Given this list of marker genes Socs1, Rhoh, Rc3h2, Ppp2r3c, Slc25a5, Il1rl2, Clcf1, H2-Aa, Slc4a2 (solute carrier family 4 (anion exchanger), member 2), Cyld, Rora, Prr7, Lmbr1l, Pck1, Cd27, Pax1, Mmp14, Cd3d, Il1a, Tusc2, St3gal1, Mir19a, H2-Oa (histocompatibility 2, O region alpha locus), Gimap1, Ptpn22, Bcl2a1d, Smarcc2, Bcl2, Tnfsf8, Foxj1 (NCBI Gene Id 15223), Zfp608, Dll4, Ccr9, Pglyrp2, Ccr6, Chd7, Smarca4, Ikzf1, Il23a, Gimap3, Il12b, Fas, H2-Ea, Ms4a1, Il2ra, Prelid1 (NCBI Gene Id 66494), Zeb1, Foxn1, Opa1, Armc5, Lrrc8a, Ctla2a, Mpzl2, Cd83, Brd4 (NCBI Gene Id 57261), Dtx1, Igkc, Pcid2, Dcaf1, Enpp1, Il9r, Brd2, Pou2af1, Traf3ip2, Lig4, Btk, Mtor, Pbrm1, Lilrb4a, Klhl25, Spib, Clec4g, Ripk3, Adam8 (a disintegrin and metallopeptidase domain 8), Tnfsf18, Tnfsf4, Shh, Fadd, Xrcc4 (NCBI Gene Id 71945), Smarcd3, Clptm1, 6030468B19Rik, Atm, Mettl3, Gimap5, Ddrgk1, Gon4l, Cdkn2a, Inpp5d, Mir92-1, Tnfsf13b, Cbfb, Ccl19, Kat7, Tcirg1, Cd3g, Blm, Dock2, Cd24a (NCBI Gene Id 12484), Ifnar2, Tnfrsf9, Pou2f2 (NCBI Gene Id 18987), Hmgb1, Malt1 (MALT1 paracaspase), Kit, Dll1, Srf, B2m, Jag2, Nkap, Zc3h8, Ptprj, Cd74, Phf14, Jmjd6, Ly6d, H2-DMa, Socs5, Mafb, Igtp, Mir18, Myb, Ptpn2, Zfp36l2, Runx3, Nfkbid, Zfp609, Dock11, Dnajb9, Actb, Itpripl1, Rabl3, Tbk1, Axl, Fbxo7, Sfrp1, Polm, Il9 (interleukin 9), Wnt1, Top2b, Stat5b, Irf1, Plcl2, Itfg2, Lgals9, Abl1, Kctd9, Il1b, Prdm1, Pf4 (platelet factor 4), Smarcd1, Dock10, Tmem131l, Zfp683, Cd3e, Pglyrp4, Itm2a, Dpp4, Cyp26b1, Fzd7, Flt3, Il21, Hdac5, Kmt2a, Foxp1, Tgfbr2, Kat2a, Il6, Btn2a2, Tnfaip3, Stat3, Eomes, Btnl6, Entpd7, Irf4, Slamf8, Notch2, Hhex, Bad, Stat4, Ap3b1, Zfp35, Txk, Gpr183, Il18r1, Slamf1, Btnl1, Gps2, Trp53, Egr3, Sox13, Sh3rf1, Rbpj, Drosha, Zmiz1, Irf8, Fzd9, Phf10, Brd7, Sash3, Sos1, Kat5, Adrm1, Ccr2, Cdk6, Batf, Ankle1, Fancd2, Itgb8, Duxbl1, Stk11, Mir17, Psmb11, Runx2, Hlx, Wwp1, Bcl6, Vsir, Ccl20, Hdac7, Cr2, Traj18, Tlr9, Ccr7, Crtam, Psap, Smarcc1, Il6ra, Rasgrp1, Mir301, Atp11c, Il15, Rorc, Tmem98, Aqp8, Fanca, Ctsl, Pik3r1, Mir150, Ifnz, Otud5, Cd4 (NCBI Gene Id 212762), Rhoa, Rnf41, Tox, Cmtm7, Plcg2, Rpl22, Cd44, Syk, Prdx2, Yy1, Slc46a2, Rsad2, Nckap1l, Card11, Smad7, Spi1, Sox12, Lgals1, Fut7, Gpr18, Nfam1, Ppp3cb, Dusp10, Ascl2, Arid2, Igkj5, Ptger4, Men1, Nkx2-3, Tyro3, Rara, Cd79b, Slamf6, Il10 (NCBI Gene Id 16153), Bcl11b, Flt3l, Cd8a, Gm11690, Il7, Ep300, Il2, Ripk2, Bax (NCBI Gene Id 12028), Ada, Nlrp3, Stat5a, Laptm5, Zbtb7a, Rps6, Vav1, Fnip1, Vnn1, Tnfsf9, Loxl3, Zc3h12a, Clec4d, Rag1, Ahr, Sart1, Il11ra1, Mir19b-1, Lep, Cd46, Lfng, Bak1, Ctla4, Adam17, Clec4e, Rc3h1, Syvn1, Il36b, Mertk, Cd40lg, Tcf3, Tpd52, Cd28, Atg5, Zbtb1 (zinc finger and BTB domain containing 1), Ighm, Arid1a, Foxo3, Apc, Pla2g2d, Pou1f1, Mfng, Fgl2, Itk, Tbx21, Pik3r6, Fzd8, Scart2, Tgfb1, Pglyrp1, Il18, Braf, Kdelr1, Lyl1, Ntrk1, Foxp3, Dnaja3, Patz1, Nhej1, Dicer1, Stat6, Cracr2a, Cebpg, Ptk2b, Lef1, Itpkb (inositol 1,4,5-trisphosphate 3-kinase B), Ptprc, Erbb2, Prkcz, Ncaph2, Nrarp, Ptpn6, Xbp1 (NCBI Gene Id 52219), Mink1, Satb1, Il7r, Hectd1, Hsp90aa1, Il15ra, Slc39a7, Zap70, Spn, Pnp, Lipa, Bcl11a, Lck, Il4i1 (NCBI Gene Id 15088), Smarcd2 (SWI/SNF related, matrix associated, actin dependent regulator of chromatin, subfamily d, member 2), Ptcra, Rag2, Lilrb4b (NCBI Gene Id 14727), Cd69, Smarcb1, Zbtb7b, Il4, Gba1, Gadd45g, Bcl3, Ikzf3, Ndfip1, Hmgb3, Actl6b, Gas6, Adgrg3, Cd79a, Wnt4, Aire, Fzd5, Il4ra, Il12a, Il27, Gata3, Hotairm1 (NCBI Gene Id 105242658), Sema4a (NCBI Gene Id 99554), Dclre1c, Kcnk18 (potassium channel, subfamily K, member 18), Nfatc1, Ezh2, Ihh, Fcer1g, Pglyrp3, Nfatc3, Nfkbiz, Xrcc6, Bmi1, Gli3, Cd19, Relb, Ighg1, Mdk, Tsc1, Abl2, Cd1d1, Atp7a, Anxa1, Cdh17, Sp3, Prex1, Itgb6, Mr1, Gm36723, Mir873a, Tespa1, Cacnb4, Ap3d1, H2-M3, Sh2b3, Wnt10b, Smarca2, Nfil3, Tshr, Fosl2, Zfp36l1, Ncor1, Id2, Hdac9, Ly9, Skint1 (NCBI Gene Id 639781), Ighe (NCBI Gene Id 380792), Lag3, Smarce1, Hspb1, Atf2, Ifnb1, Ctnnb1, Hmga1, Mir20a, Shb, Ifng, Hells, Ambra1, Runx1, Sox4, Muc19, Sos2 (SOS Ras/Rho guanine nucleotide exchange factor 2), Lepr, Mir326, Carmil2, Lgals8, Egr1, Msh2, Pbx1 (pre B cell leukemia homeobox 1), Onecut1, Actl6a, Hs1bp3, Il2rg, Irf2bp2, Jak3, Themis, Tcf7 (NCBI Gene Id 21414), Prkdc, Gpr89, Bmp4, Pknox1, Usp44, here is a description of the gene set: The process in which a relatively unspecialized precursor cell acquires specialized features of a lymphocyte. A lymphocyte is a leukocyte commonly found in the blood and lymph that has the characteristics of a large nucleus, a neutral staining cytoplasm, and prominent heterochromatin. studied in species Mus musculus Mouse Gene Set: GOBP_LYMPHOCYTE_DIFFERENTIATION